Given this list of marker genes TBCD, DNMT1, HCRT, HLA-DQB1 (NCBI Gene Id 7924), MOG, ZNF365, NPC1, NPC2, CTSH, HLA-DRB1, TNFSF4, P2RY11, here is a description of the gene set: Human Gene Set: HP_CATAPLEXY Cataplexy A sudden and transient episode of bilateral loss of muscle tone, often triggered by emotions. species: Homo sapiens